Given this list of marker genes Fsip1, Adam34l, Actl9, Adam39, Tacr1, Actr3, Adam26b, Rho, Adam6a, Pcdh11x (NCBI Gene Id 245578), Park7, Garin5b, Adam1b, Garin3, Adam20, Ddx6, Ccdc38, Plcz1, Opn4, Tacr2, Adam25, Adam6b, Hsp90ab1, Adam26a, Garin2, Adam21, Adam29, Scaper, Garin5a, Garin4, Pmfbp1, Adam34, Arpc2, Dnajb1, Wbp2nl, Cst11, Adam3, Gm4787, Adam30, Adam1a, Adam4, Adam24, Aldoa, here is a description of the gene set: The part of the late spermatid or spermatozoon that contains the nucleus and acrosome. Mouse Gene Set: GOCC_SPERM_HEAD species: Mus musculus